The following is a description of a gene set: studied in species Homo sapiens A compact and highly condensed form of chromatin that is refractory to transcription. Human Gene Set: GOCC_HETEROCHROMATIN, and this is the list of marker genes: ATRX, CBX2, SALL1, SMARCA5, CENPC (centromere protein C), HELLS, LRWD1, HMGA1, ZNF618, EME1, MACROH2A1, EED, BEND3 (BEN domain containing 3), SMARCAD1, EZH1, KDM4D, MBD2 (NCBI Gene Id 8932), ESCO2, BAZ1B, H1-5, SIRT6, UBA1, H3-4, SUV39H1, BAZ2A, TNKS1BP1 (NCBI Gene Id 85456), MECP2, ANAPC7, CENPA, FLYWCH1, TASOR, SUZ12, WDR76, INCENP, RING1, SIRT1, DDX6, RRP1B, H1-4, CHD5, H2AZ1, CBX5, EZH2, TOP2B, CHRAC1, MPHOSPH8, RNF2, CDKN2A, HMGA2, NCAPD3, CENPB, KDM4A, FOXC1, CBX6, PHC1, MORC2, POLE3, RRP8, TRIM28, MBD3, TCP1, SNAI1, UHRF2, DNMT3L, ORC2, KDM4C, PSIP1 (NCBI Gene Id 93428), SIRT2, PCGF2, BAZ1A, DNMT1, PHC2, BMI1, IKZF1, CBX3, SALL4, DNMT3A, KMT5C, CBX8, ZBTB18, NOP53, HDAC1, UHRF1, CBX1, HSF1